Given this list of marker genes ADGRG1, DMRTA2, PAX6, SHH, BMP4, EOMES, SIX3, GSX2, EMX2, BMP2, EMX1, LHX2, TRA2B, here is a description of the gene set: Human Gene Set: GOBP_TELENCEPHALON_REGIONALIZATION studied in species Homo sapiens The regionalization process that creates areas within the forebrain that will direct the behavior of cell migration in differentiation as the telencephalon develops.